The following is a description of a gene set: Mouse Gene Set: GOBP_CHEMOKINE_C_X_C_MOTIF_LIGAND_1_PRODUCTION species: Mus musculus The appearance of chemokine (C-X-C motif) ligand 1 due to biosynthesis or secretion following a cellular stimulus, resulting in an increase in its intracellular or extracellular levels., and this is the list of marker genes: Trpv4, Il17ra, Myd88, Il17a, Il17f, Tirap